The following is a description of a gene set: Genes predicted to be targets of miRBase v22 microRNA hsa-miR-106b-5p in miRDB v6.0 with MirTarget v4 prediction scores > 80 (high confidence targets). Human Gene Set: MIR106B_5P from publication Chen Y, Wang X (PMID 31504780) species: Homo sapiens, and this is the list of marker genes: PLEKHA3, ARHGAP12, ARHGEF11, FAM219B, WNK3 (NCBI Gene Id 65267), NFAT5, DNAJC16, ABCD2, PTPN3, AFG1L, AGO1, MOSMO, ANKIB1, PPP1R21, UBE2D1, CMTR2, CRY2, FBXL3, ENTPD4, CYBRD1, SLC49A4, EPHA5, DNAL1, PSD, ATG16L1, MMP2, CMPK1, TPRG1L, SPRED1, ERAP1, ZSCAN20, CCSAP, ZNF704, PLXDC2, CBLN4, C14orf28, CPEB3, PHLPP2, TUSC2, ZNF202, PKD1, SLC33A1, BICD2, TRIM3, ATXN1, ARHGEF18, OSR1, MCL1, PCDHA6, AAK1, MAP7, TAGAP, BCL11B, SCN1A (sodium voltage-gated channel alpha subunit 1), AHNAK, VSX1, WDFY3, KCNB1, UNKL, JPT1, PAPOLB, SIKE1, URI1, OSM (oncostatin M), EFCAB14, NANOS1, SALL3, BNC2, STXBP5, LDLRAP1, REV3L, PDE3B, FZD3, GLIS3, UXS1, SLC24A2, AKTIP, USP3, SSX2IP (NCBI Gene Id 22892), RCCD1, PDGFRA, ZFAND4, ARID4A, PGBD5, SNX8, FNBP1L (formin binding protein 1 like), PRRG1, ANKFY1, TGFBR2, ZBTB47, NUP35 (nucleoporin 35), BEST3, ZNF827, MYNN, VASH2, DRD1, KPNA2, BAMBI, CTSK, LMO3, KLHL2, USP46, SLITRK2, ISM2, DYNC1LI2, PAG1, SCN2B, VCPKMT, STK11, PRR16, FAM199X, FEM1C, TRIM37, NIN, MAP3K20, PDCD1LG2, SALL1, FBXO48, TXNIP, MCF2L, ZNF800, FSD1L, GNS, GXYLT1, SMAD4, TMEM168, ARMC8, ZC3H12C, WEE1, OTUD4, NDEL1, DDX5, MED12L, ZNF512B, UNC80, TMEM127, C6orf120, MINK1, SCAMP2, KIF26B (kinesin family member 26B), ANKRD29, ADAM9, TMEM64, BCL2L11, PXYLP1, ITPRIPL2, MTMR3, CDC23, RAB11FIP1, HSPA8, NR2C2, UBXN2A, OXR1, LRRC55, SLC30A7, STK38, BICC1, MFN2, ADARB1, TGM2, DCUN1D1, NTN4, RORA, CC2D1A, LYPD6, RUNX3, IRF1, ABL2, CNOT6, FBXL5, RB1CC1, BNIP2, TGFB1I1, KIAA1191, FLT1, F3, NPAT, ANKRD13C, TNFRSF21, RASGRF2, RAPH1, ZBTB4, SACS, PCDHA11, GPATCH2, PXK (PX domain containing serine/threonine kinase like), LAMA3, PHIP, ABCA1, FAM13C, CXCL6, CENPQ, TIAM1, RNF128, CLOCK, EPHA4, RBL1, NBEA, MAPK1, MTF1, ZNF148, SLC46A3, ULK1, SPOPL, PCDHA5, RGMA, RPS6KA5, SH3PXD2A, GNPDA2, PCDHA4, RHOC, TFAM, TNKS2, MAP3K2, ANO6, HAS2, MEX3D, SYTL4, TRPV6, PDLIM5, LHX6, ANKRD17, ACSL4, RRAS2 (RAS related 2), EGLN3, ZNF652, PCDH15, RAPGEFL1, RPS6KA4, JAK1, FGD4, AGTPBP1, FAS, C2CD2, SAMD12, FNDC3B, GPR63, RGMB, CCND1, APP, KCNJ10, CAPRIN2, SRCIN1, KAT2B, EIF5A2, VANGL1, CREB5, NCKAP5, FGD5, TAOK3, SH3BP5, AGFG1, ZDHHC1, KMT2B, TOPORS (TOP1 binding arginine/serine rich protein, E3 ubiquitin ligase), DNAJC27, FYCO1, LASP1, EGR2, HLF, KLHL28, CREB1, CHRM2, DPYSL5, FOXJ3, WWP2, DAB2, MAPK4, OSTM1, APCDD1, PPP3R1, PCDHA1, TENM1, PURB (purine rich element binding protein B), SSH1, USP28, FGL2 (fibrinogen like 2), PPP1R15B, TRIP11, REST, MFAP3L, NPLOC4, BTG3, TMEM167A, ATP12A, NPAS3, PLXNA1, SRGAP1, KIF23, MSR1, KLHL15, SLC4A8, IQSEC2, AKAP13, SLC4A4, MCHR2, PFKFB3, ST3GAL1, FRS2, KIAA0513, OLFM3, MIDN, ATXN7L1, LYST, CALD1, MAPRE3, MFSD8, FASTK, WFS1, NCOA3, CDC37L1, SLC16A9 (solute carrier family 16 member 9), ZFYVE9, PTPN21, SQSTM1, ERC1, PTPDC1, SORL1, TMEM138, HEG1, PTGDR, RETREG3, PTPRD, PCDHA8, SERF1A, POLR3G, TMEM100, RAB30, RAB11FIP5, TET3, LRCH1, S1PR1, LRP8, ABHD2, PCDHAC2, PSG3, ZNF597, CCNG2, PEX5L, ITGA4, THRA, ANKH (ANKH inorganic pyrophosphate transport regulator), ABHD5, MYLIP, IRF9, DDHD1, STAT3, GRAMD1A, NRIP3, MMP24, WDFY2, ANKRD33B, SERP1, TET1, ABI1, HAUS8, ARHGAP26, FAT4, RUFY2, MASTL, DPYSL2, DUSP8, NIBAN1, LAPTM4A, RACGAP1, RNF217, PHC3, BTN3A1, PCDHAC1, SLC16A6, CD69, CTSA, GAB1, ATG7, RASD1, DLGAP1, RBM12B, CAPN15, HS3ST5 (heparan sulfate-glucosamine 3-sulfotransferase 5), NABP1, RAP2C, SSH2, KPNA3, XRN1, KCNK10, ROCK2, USP32, ZNF2, PANX2, BMPR2, SMOC2, PFKP, SAR1B, RASA2, STRIP2, TRAF4, CDKN1A, TRDN, PCDHA10, CHD5, SMOC1, USP31, NPAS2, KMT5B, EREG, PGM2L1, ZBTB33, PAPOLA, IL6ST, C2orf69, B3GALT2, PCDHA7, PTGR3, AGFG2, LIMK1, TM2D2, KLF11, ZBTB18, MKRN1, TMEM265, PRR15, NEDD4L, PCDHA3, CNRIP1 (cannabinoid receptor interacting protein 1), BRWD1, RPS6KA6, GPR137B, BHLHE41, FRMD6, PCDHA13, TBC1D8B, ZNF280B, SNX16, FAM210A, UBE3C, VASP, FOXK2, IKZF4, LZIC, SFMBT1, FAM117B, CFL2, RAB12, PLS1, ZHX2, PARD6B, MAP3K8, SEMA4B, SNTB2, RAB8B, RETREG2, MAPK8, MAGI3, RRM2, PCDHA12, ST6GALNAC6, DCBLD2, ZFYVE26, NKIRAS1, RAB10, RBBP7, ENTREP2, PIK3R1, SCN2A, HECTD2, ITGB8, ST6GALNAC3, ARID4B, REPS2, TRIM36, KLF9 (KLF transcription factor 9), ZNFX1, ATG14, SRPK2, CNOT7, RLIM, ZBTB9, AP2B1, CROT, NTNG1, RRAGD, OCRL, NFIB, KMT2A, C3orf70, CRK, TMEM25, ELK3, ZBTB7A (NCBI Gene Id 56976), IL1RAP, E2F5, SLITRK3, GABBR2, REEP3, RSRP1, L3MBTL3, CD274, FAM13A, EIF4A2, FJX1, NEUROG1, NAPEPLD, ARHGEF28, CSRNP3, SPTY2D1, EEIG1, UBE2Q2, NAGK, PRDM6, SEMA7A, TRIP10, AKAP11, SCAMP5, PLAGL2, NEUROG2, ZXDA, DENND5B, PKD2, ARAP2, CMKLR1, SAMD8, NAA30, FBXO31, ZFP91, HBP1, CCDC71L, USP24, VLDLR, UEVLD, C9orf40, CLIP4, EPS15L1, PPP6C, RAB22A, FCHO2 (NCBI Gene Id 115548), BAHD1, MAP3K14, LPGAT1, ZNF25, SGMS1, PITPNA, DDIAS, EZH1, PAFAH1B1, TNFAIP1, MKNK2, TANC1, KLF12, CERCAM, LRPAP1 (LDL receptor related protein associated protein 1), ZDHHC9, SERTAD2 (NCBI Gene Id 9792), PRR14L, TNKS1BP1, LRIG1, OSBPL5 (oxysterol binding protein like 5), ATG2B, GUCY1A1, YOD1, ZBTB21, STK17B, NIPA1, RBL2, CNOT4, ARHGEF3, TRAPPC14, ABCG4, SUSD6, ANKRD50, U2SURP, MARCHF8, RNH1, LDLR, DNAJB9 (NCBI Gene Id 4189), SLC22A23, GPR6, SLC40A1, ZBTB8A, ATXN1L, RORC, SGTB, MAP10, SLMAP, ZBTB41, BBX, EPHA7, CRYBG3 (NCBI Gene Id 131544), SOCS6, RASL11B, SOWAHC, ENPP5, TBC1D20, RGL1, ORMDL3, IGSF10, MYT1L, ZBTB20, SLC45A4, PLAG1 (PLAG1 zinc finger), ETV1, KIF3B, CEP97, PCDHA2, RNASEH2B, TMX3, DUSP2, PTPN4, SUCO, PRCP, ZFPM2, RNF6, SLC17A7, TP73, MAP3K9, CEP170, TSG101, WDR37, NHLRC3, ELK4, ARHGAP1, HPS5, PPP1R3B, ANKRD52, GPR137C, GNB5, USP6, NACC2, GOLGA1, TBC1D9, KANSL1L, UNK, TBC1D17, KATNAL1, LCOR, ATL3, CAMTA1, SMAD5, DERL2 (derlin 2), E2F1, TAFA1, FBXO21, SLAIN2, ZNF367, PTHLH, AMER2, GABPB1, BRMS1L, HYCC2, BTBD7, ZNF264, FAT2, HIF1A, CNOT6L, ZNF236, CEP120, SERF1B, EMSY, SEPTIN2, SOX4, TSPAN9, GOSR1, P2RX4, BTBD10, ATAD2, HTR2A, ARHGEF10, PAK5, LIMA1, CORO2B, RAB5B, NFIC, CHP2, TAOK1, PBX3, SESN3, SOS1, DOCK4 (NCBI Gene Id 9732), DENND10, NR2C1, PLCB1